The following is a description of a gene set: studied in species Homo sapiens from publication Ceppi M, Clavarino G, Gatti E, Schmidt EK, de Gassart A, Blankenship D, Ogola G, Banchereau J, Chaussabel D, Pierre P (PMID 19943945) Dendritic cells (DCs) are the sentinels of the mammalian immune system and they undergo a complex maturation process mediated by activation upon pathogen detection. Recent studies described the analysis of activated DCs by transcriptional profiling, but translation regulation was never taken in account. Therefore, the nature of the mRNAs being translated at various stages of DC activation was determined with the help of translational profiling, which is the sucrose gradient fractionation of polysomal-bound mRNAs combined to microarrays analysis. Total and polysomal-bound mRNA populations were compared in immature (0h) and LPS-stimulated (4h and 16h) human monocyte-derived DCs with the help of Affymetrix microarrays. Biostatistical analysis indicated that 296 mRNA molecules are translationally regulated during DC-activation. The most abundant biological process among the regulated mRNAs was protein biosynthesis, indicating the existence of a negative feedback loop regulating translation. Interestingly, a cluster of 17 ribosomal proteins were part of the regulated mRNAs, indicating that translation may be fine-tuned by particular components of the translational machinery. Our observations highlight the importance of translation regulation during the immune response, and may favour the identification of novel gene clusters or protein networks relevant for immunity. Our study also provides information on the possible absence of correlation between gene expression and real protein production in DCs. Genes down-regulated in comparison of polysome bound (translated) mRNA versus total mRNA 16 h after LPS (TLR4 agonist) stimulation. Human Gene Set: GSE14000_TRANSLATED_RNA_VS_MRNA_16H_LPS_DC_DN, and this is the list of marker genes: CHURC1, C9orf85, LRRC3B, CISD2 (CDGSH iron sulfur domain 2), NUDT3, RNF11, TMA7, C4orf3, FAM222A, RALGAPA2, DUSP3, LINC00662, ARPC5L, RAB3C, RWDD1, CDKAL1, RHOQ, STARD3NL, PRR32, PTPRO, RPL10L, IL7, LSM12, AIDA, NACA2, RPL31, KATNBL1, HIKESHI, ASGR1, PRAM1, PTP4A2, JOSD1, LYRM4, ZFYVE21, GPR160, ANKRD40, YPEL3, SVIP, ANAPC16, SDF2L1, MIR155HG, MSC-AS1, ORMDL1, RFFL, LSM4, PIGH, ITGA2, SNX3, ITGAE, PTEN, CCNQ, SNHG6, ADIPOQ, TRIM69, PCP2, EIF4EBP2, CD37, EI24, SELENOH, ARRB2, ESRRA, FGFR1OP2, CAMTA1, PARP6, SLC35D2, TMIE, ARL5A, TMED2, ENSG00000284634, ZNF706, SELENOM, ICMT, NFKBID, GABPB1-IT1, HMGN1, SMUG1, FAM220A, NUDT14, GTF3A, APH1A, PSCA, STMP1, ARIH2, RPL30, BOLA3, MIEN1, PRR4, RPL37A, RPS2, LINC00477, TBPL1, UBXN2A, POLE4, TMEM42, JTB, CSNK1G2, SMIM19, RPL36, RPL13P5, TP53TG1, MMD, MZT1, PCIF1, MBOAT2, ORAI2, ZSWIM7, COX20, BOD1, C19orf12, PIGY, COMMD6, CNOT7, TXNL4A, RPLP2, PLEKHJ1, NAT16, FAM120AOS (NCBI Gene Id 158293), STYX, GTF2IRD2, ZNF273, SERP1, DTD2, ZNF688 (NCBI Gene Id 146542), TAX1BP3, SNHG16, PID1, CRNDE, NDUFA4L2, PRXL2C, AP3S1, RPL10P17, RPL23AP32, UBE2F, TMEM219, FKBP6, SSU72, PPDPF, RPL38, SMDT1, BLCAP, LST1, DPH3, EMP3, IER3IP1, GOLGA7, RPS17, SEPTIN7P2, RPS9, SURF1, MOSMO, WAC-AS1, ARHGEF25, GUK1, PDLIM2, RPL39, MRPL14, UBE2D2, NXT1, HMGN4, C7orf50, CYB561, LAMTOR1, SPATC1L, BRI3, WTAP, ENSG00000289161 (NCBI Gene Id 100310756), MBNL1, RPL23, COMMD7, RPS11, VTI1B, ZDHHC4, POLR2D, CDC26, ZDHHC2, RPS12, SVBP, ZFAND2B, GTF2H3, HOMER2, RPL27, SERF1A, HDHD5, WSB2, RBMS2, SDCBP2-AS1, FBXO24, SSNA1, CMPK1, SNF8, UBA52, TAF10 (NCBI Gene Id 6881), SMIM8, RAB31, MAIP1